The following is a description of a gene set: Catalysis of the reaction: NAD(P)H + O2 = NAD(P)H + O2-. studied in species Homo sapiens Human Gene Set: GOMF_SUPEROXIDE_GENERATING_NAD_P_H_OXIDASE_ACTIVITY, and this is the list of marker genes: NOX3, NCF4, NCF1C, NCF1B, DUOX2, NOX1, NCF2, NOXA1, CYBB, AGT, NCF1, NOX4, PDGFB, DUOX1, NOX5, CYBA, NOS3, SH3PXD2A, NOXO1 (NADPH oxidase organizer 1), SH3PXD2B